Given this list of marker genes Slk, Ttc7b, Rabac1, Tent5a, Gxylt1, Crk, Pnpla8, Sgce, Prickle2, Fam107b, Lurap1l, Brme1, Zfp398, Hbegf, Pdhb, Mex3a, Mideas, Fzd6, Tmem123, Zfp180, Kmt5a, Mid1ip1, Rapgef6, Sgpp2, Rai1, Pias2, Cul4b, Pira12, Kat6b, Gyg1, Cdk19, Tmem161b, Zfp267, Tmem43, Tmed5, Tcf24, Speer2, Col24a1, 4921517D22Rik, Zfp943, Exoc5, Rwdd4a, Smurf2, Luc7l, Klhl15, Acbd3, Epc2, Lmbr1, Hhip, Zfp950, Sdc4, Nabp1, Lrrfip1, Col14a1, Fubp3, Zfp711, Rsbn1l, Tmem106b, Plppr1, Entpd4, Lrrc4c, Sltm, Fabp12, Kmt2c, Enox1, Med4 (mediator complex subunit 4), Alppl2, St6gal2, Wnt5a, Grhl2, Hnf1b, Dgkk, Trps1, Bicd2, Ptpn20, Slc10a7, Sephs1, Scai, Utrn, Ostm1, Wapl, Cadm1, Acvr2b, Ube2d3, Itpkb, Hsf3, Rab11fip4, Nfat5, Ift74, Wdr37, Sumo2, Arid2, Snx1, Cep170, Dnajc18, Lingo2, Cln5, Myrf, Brms1l, Snap91, Nwd2, Ptpn12, Caprin1, Hmg20a, Ube2v2, Nudc, Ppp2r3a, Hspa4l, Chd1, Taf4, Bnip2, Dnajc19, Clcn5, Prkd3, Onecut2, Tmem200a, Rfx6, Dach1, Dync2li1, Oas1c, Got2, Pitpnm2, Fbxo33, Ache, Cbll1, Cln8, Trim59, Spo11, Fbxw7, Dnmt3a, Rab11fip2, Igsf11, Cep15, Hibadh, Sec24b, Ergic2, Neto1, Cdk5rap1, Dbf4, Elf4, Ark2n, Cldn1, Vmn1r45, Nrn1, Arhgap21, Hook3, Zfp462, Tmed9, Spidr, Zfhx4, Hectd2, Bckdha, Agr2, Hacd2, Trip12, Ssh2, Cert1, Osbpl8, Sox30, here is a description of the gene set: Genes predicted to be targets of miRBase v22 microRNA mmu_miR_194_5p in miRDB v6.0 with MirTarget v4 prediction scores > 80 (high confidence targets). Mouse Gene Set: MIR_194_5P from publication Chen Y, Wang X (PMID 31504780) species: Mus musculus